Given this list of marker genes LAMTOR1, RPS6KB1, PRKAB2, PRKAG3, RRAGC, TNRC6A, LAMTOR2, LAMTOR3, STRADB, LAMTOR4, MIR142, MTOR, AKT2 (NCBI Gene Id 208), AGO2, PPM1A, STK11, RHEB, TNRC6B, AKT1, LAMTOR5, RRAGA, EIF4B, TNRC6C, YWHAB, EIF4G1, AGO1, MOV10, RRAGD, SLC38A9, EEF2K, PRKAG2, STRADA, MLST8, TSC1, PRKAG1, CAB39L, RPS6, AGO3, AGO4 (NCBI Gene Id 54791), RRAGB (NCBI Gene Id 10325), FKBP1A (NCBI Gene Id 2280), CAB39 (calcium binding protein 39), PGK1, EIF4EBP1, PRKAA1, AKT1S1, PRKAB1, AKT3, PRKAA2, EIF4E, RPTOR, TSC2, here is a description of the gene set: Reactome Pathway: MTOR signalling part of: Signal Transduction Mammalian target of rapamycin (mTOR) is a highly conserved serine/threonine kinase that regulates cell growth and division in response to energy levels, growth signals, and nutrients. Control of mTOR activity is critical for the cell since its dysregulation leads to cancer, metabolic disease, and diabetes (Laplante & Sabatini 2012). In cells, mTOR exists as two structurally distinct complexes termed mTOR complex 1 (mTORC1) and mTOR complex 2 (mTORC2), each one with specificity for different sets of effectors. mTORC1 couples energy and nutrient abundance to cell growth and proliferation by balancing anabolic (protein synthesis and nutrient storage) and catabolic (autophagy and utilization of energy stores) processes. mTORC2 is responsive to growth factor signaling. mTORC1 and mTORC2 cross-talk through AKT and S6K. Rapamycin, the inhibitor of mTOR, inhibits only mTORC1, as the RICTOR subunit of mTORC2 masks the rapamycin-interacting domain of MTOR in mTORC2. species: Homo sapiens